The following is a description of a gene set: Any process that increases the rate, frequency or extent of SMAD protein signal transduction. Mouse Gene Set: GOBP_POSITIVE_REGULATION_OF_SMAD_PROTEIN_SIGNAL_TRANSDUCTION species: Mus musculus, and this is the list of marker genes: Gdf6, Acvr1, Tgfbr1, Tgfb2, Nodal, Bmp6, Bmp10 (bone morphogenetic protein 10), Glce, Pparg, Lgals9, Gdf11, Smad4, Bmpr2, Smad3, Nup93, Eng, Gdf5, Tgfbr3, Hfe, Tgfb1, Bmp5, Bmper, Acvr2a, Atoh8, Amh (NCBI Gene Id 11705), Bmpr1a, Dab2, Gdf2, Tgfb3, Sh2b1, Jak2, Tgfbr2, Parp1, Acvrl1, Csnk2b, Bmp2, D130043K22Rik, Bmp4, Inhba, Gdf7, Bmp7 (NCBI Gene Id 12162), Twsg1